Given this list of marker genes PTN, ZP3P2, RPS3AP27, AKR1B10, CHRM2, MIR490, AGBL3, CREB3L2, PSMC1P3, CALD1, ENSG00000232053, TUBB3P2, RNF14P4 (NCBI Gene Id 100419645), LRGUK, CHCHD3, RNU6-223P, SLC23A4P (NCBI Gene Id 649739), STRA8, PTMAP10, TRPC6P8, DGKI, COX5BP3, SLC35B4, RPL6P19, MIR3654, AKR1D1, LINC03060, MIR6133, TMEM140, SLC13A4, AKR1B15, RCC2P3, RNU6-1154P, RN7SKP223, KRT8P51 (keratin 8 pseudogene 51), CYREN, BPGM, NUP205, MTPN, EXOC4, CREB3L2-AS1, TRIM24 (NCBI Gene Id 8805), MIR4468 (NCBI Gene Id 100616226), SNORD81, IMPDH1P3, ENSG00000225559, RPS3AP28, ST13P7 (ST13, Hsp70 interacting protein pseudogene 7), AKR1B1, FAM180A, STMP1, ENSG00000234352, CNOT4, RPL15P11, RNU6-92P, SDHDP2, MIR6509, ENSG00000201465, WDR91, here is a description of the gene set: studied in species Homo sapiens Human Gene Set: chr7q33